Given this list of marker genes Ripor2 (RHO family interacting cell polarization regulator 2), Ptger4, Trem3, Pawr, Mdk, Cd99l2, Pecam1, Fut7, Cd177, Ptger3, Jaml, Trem1 (triggering receptor expressed on myeloid cells 1), Il1r1, Prtn3, Adam8, here is a description of the gene set: Mouse Gene Set: GOBP_NEUTROPHIL_EXTRAVASATION studied in species Mus musculus The migration of a neutrophil from the blood vessels into the surrounding tissue.